The following is a description of a gene set: species: Homo sapiens Human Gene Set: GOBP_SPERMATID_DIFFERENTIATION The process whose specific outcome is the progression of a spermatid over time, from initial commitment of the cell to a specific fate, to the fully functional differentiated cell., and this is the list of marker genes: VDAC3, UBE2B, PTCH1, KAT5, MEIG1, FXR1, SRPK1, CDYL, BBOF1, SEPTIN4, ROPN1B, FANCG, AGFG2, BAX, SIX5 (SIX homeobox 5), TSSK2, TCP11X1, RSPH1, ROPN1L, IFT81, CCNB1IP1, C2CD6, QKI, DDX6, SUN5, TARBP2, ADAM7, IFT56, FAM9B, CATSPERZ, ADGRG2, VPS54, ACTL7A, JAM3, STRBP, CFAP206, SEMG1, DNALI1, CHN2, SPAG16, SPO11, GK2, TTLL1, SLC26A6, CFAP69, CFAP44, CFAP43, SPEF2, TMF1, FREY1, CHD5, CCDC146, GLI1, KLC3, DDX25, PLA2G3, DNHD1, CCDC63, SOX30, TDRD5, FNDC3A, ADCY10, MEIOC, TNP2, ZPBP2, IZUMO3, PANK2, NPHP1, ACTL9, GARIN4 (golgi associated RAB2 interactor family member 4), PRM2, CABYR, CCDC159, GARIN1B, SLC26A3, MKKS, HOOK1, CCDC136, TSSK6, ZMYND12, ARMC12, SPACA1, H3-3A, SPANXB1, TMPRSS12, CFAP52, EPC1, TBPL1, CEP57, PCSK4, FAM9A, PRM1, SLIRP, H1-7, RIMBP3, RBM46, EHMT2, NEURL1, RSPH6A, SLC22A14, TPGS1, PLN, CEP131, UBE2J1, ADGB, TCP11, CIB1, VPS13B, PSME4, SPATA16, RHBDD1, TNP1, STK33, NSUN2, ACRBP, TTC12, BBS4, CATSPERE, CYLC1 (cylicin 1), MAST2, PIWIL1, DYNLL1, ROPN1, RIMBP3B, PMFBP1, EIF4G3, RNF8, AXDND1, IQCG, SEPTIN14, GARIN1A, PRKG1, KIT, ADAD2, SPINK1, DCAF17, ZPBP (NCBI Gene Id 91091), TTC21A, ELSPBP1, PYGO1, POC1B, YTHDC2, PRKACA, CATSPER2, DZIP1, PYGO2, SMARCA2, IQCF1, NECTIN2, FAM9C, H3-3B, PLD6, PACRG, KDM3A, CCDC62, GALNTL5, TRIP13, DRC1, CAPZA3, ARMC3, KIAA0319L, OSBP2, DMC1, CCER1, SUFU, SPACDR, CFAP53, TSSK4, AKAP4, CATSPER4, PAEP, CATSPERD, TSSK1B, RAN, CFAP57, RIMBP3C (RIMS binding protein 3C), BRDT, H2BC1, ARMC2, DRC7, CFTR, ING2, BRIP1, GARIN3 (golgi associated RAB2 interactor family member 3), SPAG6, ZMYND15, MFSD14A, RNF17, CFAP54, KLHL10, TUBA8, SLC9A8 (solute carrier family 9 member A8), AGFG1, ADAD1, SPEM3, DHH, CFAP61, CCDC42, SELENOF, DPY19L2, CCR6, ICA1L, KNL1, SPAG17, SBF1 (NCBI Gene Id 6305), HSPA2, TTLL5, TSSK3, TBC1D20, CEP128, RFX2, CFAP157, SYCP3, REC8, DMRTC2, CFAP119, PITHD1, PDCL2, SPPL2C, TBC1D21, BBS2, DNAH1 (dynein axonemal heavy chain 1), AFF4 (NCBI Gene Id 27125), NUP210L, FSIP2, JAM2, SPEM1, CFAP65, CFAP97D1, PFN4, LRRC46, MNS1, SEMG2, TMEM119, SYCP1, YIF1B, SPINK2, EFCAB9, DPY19L2P2 (NCBI Gene Id 653912), CCDC38, CFAP47, PDILT, CFAP58, PAFAH1B1, IQCN, HMGB2, TCP11X2, DEFB1, OCA2, DLD, ABHD2, BSPH1, NME5, FSHR, CATSPER3, CFAP221